The following is a description of a gene set: Human Gene Set: GOBP_POSITIVE_REGULATION_OF_TRANSFERASE_ACTIVITY Any process that activates or increases the frequency, rate or extent of transferase activity, the catalysis of the transfer of a group, e.g. a methyl group, glycosyl group, acyl group, phosphorus-containing, or other groups, from a donor compound to an acceptor. species: Homo sapiens, and this is the list of marker genes: JAK2, PTK2B, NEK10, ADIPOQ, PIK3R5, MT3, ARHGEF5, MAP2K2, MAP3K7, RFC3, ELANE, PABPN1, TNFRSF10A, MAP2K1, HMGA2, ABI1, RIPK3, BTRC, WNT5A, XRCC6, PILRB, CRIPTO, HLA-DRB1, MAP3K11, UBE2S, CARD14, PRKCD, CARD10, NEDD9, TNF, ARRDC4, TNFSF15, MAGEA2, GPRC5B, FGFR1, RFC5, ZFP91, CD74, JTB, ETAA1, ERN1, S100A12, DRD4, FGF1, EREG, LCP2, PLK1, TLR6, LTF, RALB, ITGB1BP1, CDC14B, MAP2K3, STOX1, ADCYAP1, CENPE, ANGPT1, TPD52L1, PLAAT4, TCIM, PPIA (peptidylprolyl isomerase A), COPS8, PTK2, TLR3, POLG2, DBI, LEP, RFC4, PCNA, CAMK1, CACUL1, ADAM17, CAB39, SASH1, SYAP1, ALS2, ABL1, EEF1A2, LILRA5, TPX2, SRC, IRGM, TNFRSF10B, XRCC5, UNC119, DSTYK, STK11, RASSF2, DIRAS1, TRAF6, IGF1, CLSPN, BMI1, CCNY, SRCIN1, RFC2 (NCBI Gene Id 5982), TIGAR, UBE2C, DSCC1, TAB2, PRLR, CASS4, TAOK3, MAGEA2B, IFNG, TENM1, CDKN1A, DDR2, FBN1 (fibrillin 1), FLT1, RAP1A, PIK3R6, PDGFB, STRADA, NRG1, MAP3K5, PIH1D1, SKP1, TOM1L1, ZNF16, MMD2, DIPK2A, EZH2, PIBF1, RAPGEF2, FLT3, MRNIP, MMD, PTPRC, ZNF622, ERBB2, FZR1, MST1R, DOK7, PIK3CG, MAP4K2, CDC20, CEMIP, KIF14, SNX9, LAT, TRAF2, ARRDC3, RASGRP1, CIB1, SIRT1, CHTF8, AGAP2, PDGFRB, CIMAP3, RHOA, FGF18, PIM1, CSF1R, MAP3K10, SPDYA, MAP3K4, CCDC88A, GAS6, ADCY8, FGF2, STRADB, CD4, ECT2, DYNAP, DIRAS2, LMO4, PTPN1, CHTF18, CHI3L1, TRAF4, CALCA, RPS2, PSMD10, MAGEC2, PDCD10